The following is a description of a gene set: studied in species Homo sapiens Genes having at least one occurrence of the motif VCCGGAAGNGCR in the regions spanning 4 kb centered on their transcription starting sites. This matches the GABPA, GABPB2 transcription factor binding site V$GABP_B (v7.4 TRANSFAC). Human Gene Set: GABP_B, and this is the list of marker genes: TENT5A, TOMM40, HERPUD2, SNIP1, AAK1 (AP2 associated kinase 1), CHERP, NUP153, ZNF485, TMBIM4, RAB11B, LRRC41, TBP, GPANK1, EIF3H, MAGED2, MTMR14, RPL32, BANF1, ANKRD17, EXTL2, ZNF384, SF3B3, KXD1, TRMT2A, DDX1, BTBD1, TCTA, MAD2L1BP, SPG21, UBE2F, CSTF1, RANBP1, PCBP2, CEP95, TBX6, IDH3G, LOXL3, SYNRG, TAF10, KLHL17, DNAI1, HPS1, ZNF35, NUP155, UPF2, KIF4A, SEC11A, ASXL2 (NCBI Gene Id 55252), COQ10B, SCAMP2, CCZ1B, CSAD, PPP1R21, SLC30A7, PCBP4, RBM22, BAG4, ACIN1, EIF5A (eukaryotic translation initiation factor 5A), XRCC4, SLC39A6, ZNF394, PRKAB1 (protein kinase AMP-activated non-catalytic subunit beta 1), POMP, LSM1, EDC4, TSTD2, LDOC1, ATM, U2AF2, ZNF653, MTPN, TMEM208, RPL34, DNTTIP1, THG1L, ZBTB26, NAA60, SUV39H1, DIAPH1, CHPF, APOLD1 (apolipoprotein L domain containing 1), SUPT5H, ATG5, STK10, TRO, DDIT3, PAFAH1B2, BRCC3, POU3F3, ZNF23, EMG1, MLEC, KICS2, ZNF24, KAT5, DCAF10 (NCBI Gene Id 80211), C14orf119, RHOA, NPAT, DLX4, TMEM127, NCBP1, CARF, DTX2, ACP2, TM2D3, TRIM39, RHOT2, SHKBP1, ISCU, CLMN, TSSK1B, GNB2, ACTB, NMNAT1, CD2BP2, UBXN1, PIGW, PHF6, UGGT2, CCDC85B, PIGO, PYM1, EXOSC3, RNPS1, CYB5R4, CRB3, CPEB4, ASPHD1, RPS6KA3, CDK9, MYG1, SMC6, FIBP, GALNT10, WDR1, DOK1, USB1, DIS3L2, ELK3, PHB2, SSR4, MRPL3, EBNA1BP2, SF3B4, DNAJC7, GTSF1, FBXO36, RAB7A (NCBI Gene Id 7879), CLDN12, SART3, TAF5L, USPL1, ZSCAN20, PCGF1, MOCS3, DDOST (dolichyl-diphosphooligosaccharide--protein glycosyltransferase non-catalytic subunit), PHF23, ELP2, PATZ1, RABEPK, RPL34-DT, PSME3IP1, ARRB2, EXOC5, CAP1, TOMM22, LINC03124, ZDHHC5, C9orf40, SEC31A (NCBI Gene Id 51424), MON1B, AP1M1, TRIM44, PHF20L1, FBXL9P, SYT5, DPM1, CCDC71, EDRF1, MAPRE1, IQGAP1, VPS16, EMC4, CPSF7, HARS2, COG4, GNL3L, LSR, LZIC, AURKA, ZFYVE16, MPZL3, AGL, CELF1, PHLDB3, CSNK2B, UQCRH, PPME1, RBMS2, STK35, DDX5, ZBTB41, TMUB1, TMCO1, SUPT16H, WFDC3, WDR74, EPN1, PLA2G4D, PCED1A, ZNF322, FAM219A, SLC38A10, MTCP1, SF3A1, LEPROTL1, PCBP1, B3GAT3 (beta-1,3-glucuronyltransferase 3), ATP7A, ZNF79, MORC3 (NCBI Gene Id 23515), CFAP57, VPS53, PPP1R11, PDZD11, PER2, DERL1, TMX1, CCDC6, COX6A1 (NCBI Gene Id 1337), NKIRAS2, VPS13B, NF1, USE1, MYO19, NIPBL (NIPBL cohesin loading factor), LSM5, SRP54, PRKAG2, DPP8, TAOK2, UBE2N, MRPS21, CRIPT, PER1, FRS2, PSMB1, RSPRY1, BCAT2, SDHAF2, SCAMP3, CSGALNACT2, GTF2A2, NOC2L, CPT2, RAB5C, NRAS (NRAS proto-oncogene, GTPase), CIAO1, GEN1, AP5M1, EIF1AD, PIGF, ZNF687